The following is a description of a gene set: Mouse Gene Set: GOBP_CELL_COMMUNICATION_INVOLVED_IN_CARDIAC_CONDUCTION species: Mus musculus Any process that mediates interactions between a cell and its surroundings that contributes to the process of cardiac conduction. Encompasses interactions such as signaling or attachment between one cell and another cell, between a cell and an extracellular matrix, or between a cell and any other aspect of its environment., and this is the list of marker genes: Kcnn2, Kcnj5, Kcnq1, Trpm4, Hrc, Scn3b (NCBI Gene Id 71632), Gjd3, Scn4b (NCBI Gene Id 399548), Slc8a1, Nup155, Flna, Kcne5, Ank2 (NCBI Gene Id 99906), Cacnb2, Pkp2, Gjc1, Dsp, Dsg2, Rangrf, Scn5a, Gja1, Dsc2 (desmocollin 2), Ctnna3, Hcn4, Tbx5, Cav1, Tnni3k, Ryr2, Pde4d, Sri, Cacna2d1, Cacna1c, Tbx18, Gja5, Cxadr, Cacna1d, Irx3, Scn1b, Jup, Kcna5, Scn10a